Given this list of marker genes PDGFB, NR1H4, LDLR, DNAJC19, SPATA18, PHB2, PDGFA, ABCA2, LPCAT1, SCP2, MTMR2, ABCA3, MTMR1, MFSD2A, LPIN1, CAPN2, HTR2A, XBP1, MIR30C1, FABP3, TAFAZZIN, ACSL3, MTMR9, HTR2B (5-hydroxytryptamine receptor 2B), PRKCD, MTMR3, APOC2, GNB3 (NCBI Gene Id 2784), APOC1, CHP1, CHRM5, HTR2C, SCARB1, IDH1, RAB38, ENPP7, ADGRF5, here is a description of the gene set: Human Gene Set: GOBP_REGULATION_OF_PHOSPHOLIPID_METABOLIC_PROCESS species: Homo sapiens Any process that modulates the frequency, rate or extent of phospholipid metabolic process.